Given this list of marker genes Fosb, Junb, Zfp36, Dusp1, Klf2, Fos, Hspa1a, Atf3 (activating transcription factor 3), here is a description of the gene set: Mouse Gene Set: CUI_CDC2_IL17D_RESPONSE_DN studied in species Mus musculus Genes negatively differentially expressed in cell type: cDC2 (conventional dendritic cell type 2) upon treatment with cytokine: IL-17D in mouse lymph nodes in vivo. from publication Cui A, Huang T, Li S, Ma A, Pérez JL, Sander C, Keskin DB, Wu CJ, Fraenkel E, Hacohen N (PMID 38057668) Cytokines mediate cell-cell communication in the immune system and represent important therapeutic targets. A myriad of studies have highlighted their central role in immune function, yet we lack a global view of the cellular responses of each immune cell type to each cytokine. To address this gap, the authors created the Immune Dictionary, a compendium of single-cell transcriptomic profiles of more than 17 immune cell types in response to each of 86 cytokines (>1,400 cytokine-cell type combinations) in mouse lymph nodes in vivo. A cytokine-centric view of the dictionary revealed that most cytokines induce highly cell-type-specific responses. For example, the inflammatory cytokine interleukin-1β induces distinct gene programmes in almost every cell type. A cell-type-centric view of the dictionary identified more than 66 cytokine-driven cellular polarization states across immune cell types, including previously uncharacterized states such as an interleukin-18-induced polyfunctional natural killer cell state.